The following is a description of a gene set: Mouse Gene Set: GOBP_MRNA_5_SPLICE_SITE_RECOGNITION Recognition of the intron 5'-splice site by components of the assembling spliceosome. studied in species Mus musculus, and this is the list of marker genes: Sfswap, Psip1, Srsf1, Prpf39, Snrpc, Srsf12